Given this list of marker genes PIM1, C1orf174, SOD2, CISD1, CLEC10A, NUDT22, ATP6V0A1, SAP18, DKK2 (NCBI Gene Id 27123), EQTN, RYK, PDK2, PASK, NME1, SMG5, EMC8, WDR4, TST, FLYWCH2, C19orf73, ADAMTS15, TG, TMX2, DCTN6, RSPO1, KIF5A (kinesin family member 5A), TUBB3, CRISP3 (cysteine rich secretory protein 3), TIMM50, SNRNP25, WWP2, NUDT1 (nudix hydrolase 1), CA4, CLIC3, GLO1, B4GALT5, REG3G, KIFC3, UXT, SLC46A1, C11orf52, TSKU, LBX2, EXOSC7, GCK, DLX5, RAD51B, LAMC3, DNAH8 (NCBI Gene Id 90022), FPR2, PTK6, MLH1, GLRX2 (glutaredoxin 2, NCBI Gene Id 51022), AIPL1, DNASE1L1 (NCBI Gene Id 1774), SYCP3, ACADVL, KRTDAP, CYP2S1, PIK3C2G, SFTPA1, TM7SF2, ARSG, CINP, PIGP, BOLA1, DDIT4L, NDUFS6, DUSP14, WDR31, GAB1, CCL25, NNMT, METTL8, MORC4, CCDC159, CDK5RAP1, AP4M1, ASB12, RSPH9, MYG1, NDUFB2, NDUFA12 (NADH:ubiquinone oxidoreductase subunit A12), XPNPEP1, SLC29A2, OR4E2, PLXNB3, CLDN18, TSSK6, WNT9A, BHLHE40, GARS1, TNFRSF17, ELOVL4, ANXA9, PROK2, AP2A2, RLN1, PPIE, ELMO3, FAM81A, CCL24, TRAPPC2B, SLC13A3, NPPA, FAF1, MANBAL, CA13, ADAT2, MMP17 (NCBI Gene Id 51403), RBBP4, OARD1 (NCBI Gene Id 221443), MYF5, IFNG, TRIR, PECR, B3GALT5, SOX12, SMDT1, RITA1, CSTA, NDUFS3, KLF3, SLITRK1, CLDN7, COX6A2, ZNHIT3, PABIR1, ADARB1, ADGRD1, AMZ2, KMT5A, VAMP5, NTRK3, PTGR1, TUBG2, IQCC, AKAP1, CXCR6, NSMCE1, RERG, MRPL46, GPR89B (NCBI Gene Id 728932), ARMC6, WDR83, PRSS37 (serine protease 37), POLR2C, FGF23, POLR3H, TPSG1, CFHR1, HOXD4, UQCR10, LSM3, TIMM8B, MRPS18A, NOLC1, RELL1, NAA38, MRPL55, COX6B1, HSD3B2 (hydroxy-delta-5-steroid dehydrogenase, 3 beta- and steroid delta-isomerase 2), HAUS8, NEU3, ESR1, UPK3B, CLPP (NCBI Gene Id 8192), PSMC3, ATP5ME, CCR10, THYN1, MRPS33, MICOS10, COL9A2, DPEP1, DUSP9, RBKS, PDPN, MRPL40, TRO, PFDN6, DECR1, HTR2C, ADRB3, ACOT8, KRT7, MRPL48, CABP7, CCDC70, TRUB2, SLC35B1, CYYR1, PRDX4, MYO5B, TNFRSF8, FARP2, EGFL6, ATP6V1E1, LCMT1, CENPO, here is a description of the gene set: studied in species Homo sapiens Th17 cells are enriched by sorting FR4-CD4+ T cells from SKG mice. A large number of Th17 cells also develop spontaneously when CD4+ T cells from IFN-g-deficient (IFN-g-/-) BALB/c mice are transferred to T cell-deficient RAG2-deficient (RAG2-/-) mice and subjected to homeostatic proliferation, whereas they fail to develop in similar transfer of IL-6-deficient (IL-6-/-) CD4+ T cells to IL-6-/- RAG2-/- mice. To explore the functional molecules specifically expressed by Th17 cells, we conducted Gene Microarray analysis between 10-month-old SKG FR4-CD4+ cells and age-matched BALB/c FR4-CD4+ cells, and between IFN-g-/- CD4+ cells transferred to RAG2-/- mice and IL-6-/- CD4+ T cells transferred to IL-6-/- RAG2-/- mice. The analysis revealed that 1,556 and genes were up-regulated in 10-month-old SKG FR4-CD4+ and IFN-g-/- CD4+ T cells after homeostatic proliferation, respectively, with genes shared by the two groups of genes. The genes included those encoding cytokines, chemokines, and their receptors, such as IL-1 receptor type1 (IL-1R1), IL-17, IL-22, IL-21, CCR6, and CCL20. Genes up-regulated in FOLR4- CD4 T cells treated by phorbol myristate acetate and ionomycin from: BALB/c versus SKG mice. Human Gene Set: GSE9316_CD4_TCELL_BALBC_VS_TH17_ENRI_CD4_TCELL_SKG_PMA_IONO_STIM_FR4NEG_UP from publication Hirota K, Yoshitomi H, Hashimoto M, Maeda S, Teradaira S, Sugimoto N, Yamaguchi T, Nomura T, Ito H, Nakamura T, Sakaguchi N, Sakaguchi S (PMID 18025126)